The following is a description of a gene set: Human Gene Set: GOCC_ACTIN_FILAMENT studied in species Homo sapiens A filamentous structure formed of a two-stranded helical polymer of the protein actin and associated proteins. Actin filaments are a major component of the contractile apparatus of skeletal muscle and the microfilaments of the cytoskeleton of eukaryotic cells. The filaments, comprising polymerized globular actin molecules, appear as flexible structures with a diameter of 5-9 nm. They are organized into a variety of linear bundles, two-dimensional networks, and three dimensional gels. In the cytoskeleton they are most highly concentrated in the cortex of the cell just beneath the plasma membrane., and this is the list of marker genes: PDLIM1, AFAP1, AVIL, PDLIM2, MYO5A, ACKR2, POTEF, PAK1, AIF1L, PLS1, PDLIM5, FMN1, DUSP22, PLS3, SH2B2, VPS18, GDPD2, SHROOM4, FYN, BLOC1S6, POTEI, SPECC1, PDLIM4, GJB6, SPTBN4, APC2, ACTB, PRICKLE4, DIAPH2, ARPC3, TWF1, POTEE, RCSD1, NCKAP1, POTEKP, AMOT, WIPF1, GAS2L1, YES1, RAC3, ANXA1, CTTN, ACTN2, DPYSL3, MICAL2, ACTN1, POF1B, TPM4, TMOD1, RAC2, FHDC1, PAWR, DMTN, TWF2, PALLD, GAS2, FLNA, RHOQ, LCP1, LDB3, MYO1A, MICAL1, TSC1, MYO3A, TPM2, ACTL8, DIAPH3, CORO1A, POTEJ, SPECC1L, PDLIM3, WAS, CARMIL1, DIAPH1, TPM3, EZR, PDLIM7, COBL, DNAJA3, JAM3, LIMA1, MYO18B, SRC, HCK, COTL1, AIF1, ACTA1 (actin alpha 1, skeletal muscle), WHRN, LUZP1 (NCBI Gene Id 7798), INF2, ACTG1, ACTBL2, MYO6, ACTC1, MYO1C, GAS2L2, MISP, TPM1, LMOD1, TEK, KPTN, ESPN, CORO1B, ARHGAP6, IQGAP1, KEAP1, DYRK1A, MYO9A, RAC1 (NCBI Gene Id 5879), LMOD2, ABI2 (NCBI Gene Id 10152, abl interactor 2), MARK2, CD2AP, MYO9B, ACTN3, MYO1B